Given this list of marker genes COL6A3, COL6A1, COMP, COL6A2, COL12A1, here is a description of the gene set: Human Gene Set: HP_INCREASED_LAXITY_OF_FINGERS species: Homo sapiens Increased laxity of fingers